Given this list of marker genes Plpp1, Sgpp1, Sgpp2, Plpp2, Plpp6, Plpp3 (NCBI Gene Id 68448), Plpp7, here is a description of the gene set: Catalysis of the reaction: sphingosine 1-phosphate + H2O = sphingosine + phosphate. species: Mus musculus Mouse Gene Set: GOMF_SPHINGOSINE_1_PHOSPHATE_PHOSPHATASE_ACTIVITY